Given this list of marker genes Ptk2b, Cav3, Agrn, Bin1, Kcne3 (NCBI Gene Id 80572), Nedd4l (NCBI Gene Id 83814), Casq2, Crbn, Grp, Hcrt, Adcyap1, Akap5, Kcnq1, Kcnab1, Gnaq, Htr2a, Nos1, Plcb4, Oxsr1, Kcnrg, Kcnh2, Kcne5, Atf4, Ank3 (ankyrin 3, epithelial), Nos3, Cav1, Vip, Kcne1, Ptger3, Kel, Kcne2, Rgs4, Actn2, Sumo1 (NCBI Gene Id 22218), Stk39, here is a description of the gene set: Mouse Gene Set: GOBP_NEGATIVE_REGULATION_OF_POTASSIUM_ION_TRANSPORT Any process that stops, prevents, or reduces the frequency, rate or extent of the directed movement of potassium ions (K+) into, out of or within a cell, or between cells, by means of some agent such as a transporter or pore. studied in species Mus musculus